The following is a description of a gene set: The presence of any abnormality affecting the abdominal wall. species: Homo sapiens Abnormality of the abdominal wall Human Gene Set: HP_ABNORMALITY_OF_THE_ABDOMINAL_WALL, and this is the list of marker genes: SKIC3, CHD3, CTNNB1, SKIC2, MED13L, ZFP57, TRIM8, IDUA, SET, RIN2, RPL10, SMARCC2, TGFB3, FOXE3, DNAJC30, PIK3CD, SKI, SEC31A, NOTCH2, GLRB, EHMT1, SEMA3E, RNF13, TBXT, ZIC3 (Zic family member 3), GRM7, AP1S2, GNE, CDH11, SETBP1, POU1F1, ATP6V1A, CHD7, LMOD1, MID1, ACTA2, RAC1, FLNB, LRP2, FANCM (FA complementation group M), TGFBR2, CDKN1C, VPS37D, PPP1R12A, ERCC2, AUTS2, DIS3L2 (DIS3 like 3'-5' exoribonuclease 2), CBL, BUD23, SLC5A5, DYNC2I1, GPC3 (glypican 3), SCN2A, FANCF, DUOX2, SNIP1 (NCBI Gene Id 79753), RIPPLY2, PACS1, RRAS, CRKL, ACTG2, MEIS2, MTOR, RFWD3, IKBKG, TMEM67, CDCA7, FOXE1, NFIA, TASP1, FANCI, GTF2I, NOTCH3, SLC2A10, PIGY, PRKG1, SRCAP, KNSTRN, IRX5, PLD1, PIGW, HIRA, MEG3, KMT2D, MBTPS2, MRAS, SMARCA2, AGA, PTCH1, MLXIPL, PIGQ, CAPRIN1, SMAD4, DNMT3B, CTCF, POLR2A, IFT80, ZBTB24, WNT3, AARS1, BCL11B, PNKP, DYRK1A (NCBI Gene Id 1859), LMNA, ABCD4, CHRM3, GTF2H5, CARS1, SALL1, FOCAD, ZEB1, NFIX, UBA1, FLNA, IRF6, B3GAT3, BAZ1B (bromodomain adjacent to zinc finger domain 1B), HES7, RFX7, WDR35, GDF11, CDKL5, KDM3B, CCDC22, GNS, PRKG2, GLB1, RREB1 (NCBI Gene Id 6239), CHAMP1, CLDN19, ATP6V1E1, GPHN, UFD1, APC2, PROP1, DNMT3A, EFNB1, BGN, TSHB, CC2D2A (coiled-coil and C2 domain containing 2A), ZMPSTE24, MYH3, TBX1, MBTPS1, ZBTB7A, DUOXA2, MEGF8, NOTCH1, PIGS, TBCK, DYNC2H1, PRDM5, GJA1 (NCBI Gene Id 7953), EOGT, FRAS1, SLC10A7, FANCA, COX11, TRPV6, ARVCF, NKX2-1, PLAGL1, ABCC8, IGF2, FANCB, PRR12, PIGN, MTFMT, GMNN, PAX8, DLL3, GLIS3, PPIB, ELOVL4 (ELOVL fatty acid elongase 4), TXNL4A, CHUK, DHCR7, ELMO2 (NCBI Gene Id 63916), XRCC4 (X-ray repair cross complementing 4), WDR19, SIK1, SLX4, ATRX, SGSH, RRAS2 (NCBI Gene Id 22800), FGFR1 (fibroblast growth factor receptor 1), MYLK, SMAD2, COLEC10 (collectin subfamily member 10), IFT140, BCOR, FANCC, PLOD2, NEUROD2, FARSB, RPS6KA3, FTO, MMP2 (matrix metallopeptidase 2), SLC35D1, EIF4H, RAB3GAP2, GRIN1, MCOLN1, CSGALNACT1, C1R, MASP1, ERI1, KCNQ1, VPS35L, DGCR6, ODC1 (ornithine decarboxylase 1), ALDH18A1, LFNG, TUBB, RASA2, UBE2T, CWC27, DVL3, USP9X, ARID1A, BRF1, PIEZO2, AMHR2, COL11A2, LRPPRC, KRT1, COL1A1 (collagen type I alpha 1 chain), TGFBR1, UHRF1, RIC1, RIPK4, HSPG2, NAT8L, ATP6V0A2 (NCBI Gene Id 7854), XYLT1, FANCE, FANCD2, FREM2, BRAF (B-Raf proto-oncogene, serine/threonine kinase), FOXF1, DGCR2, LTBP4, STX1A, FZD2, RIT1, LZTR1, ARID1B (AT-rich interaction domain 1B), AMH, CEP120, DACT1, GTF2E2, TGDS (NCBI Gene Id 23483), ATAD1, LHX4, MAT2A, AHDC1, DYNC2I2, OFD1, HEY2, OCLN, CHST14, G6PC3, LIMK1, OCRL, PAH, COL5A1 (collagen type V alpha 1 chain), JMJD1C, CLIP2, IFT81, EED, GRIN2B, HIVEP2, INPP5E (inositol polyphosphate-5-phosphatase E), MYH11, SLC35C1, MAD2L2, KAT6A, ALG9, RAD51, KCNH1, SMARCB1, LONP1, RMRP, BRCA2, SPECC1L, GRIP1, ROR2, RNF2, PLCB4, CCBE1, GTF2IRD2, NDUFA8, SEMA5A, SLC32A1, TENT5A, BCR, TMEM270, GAD1, HIC1, LBR, NSD1, NPHP3, RPGRIP1L, LTBP1, GTF2IRD1, TPO, TMEM94, ERCC3, BSCL2, FAT4, MED12, TARS1, CREBBP, RTL1 (retrotransposon Gag like 1), IFT56, RAF1, THRA (thyroid hormone receptor alpha), MTHFR, YWHAE, DPH1, PI4KA, SLC5A6, SLC26A4, TBX3, LHX3, FKBP6, PYCR1, SLC37A4, HESX1, MAF, KDM6A, TMEM107, HMGA2, FGD1, COL3A1, IPO8, TG, POLR1A, DVL1, MKS1, SH3PXD2B, ZFX, SOS1, PIGL, TAF4, MESP2, SUZ12, COMT, DMXL2, MAN2B1, SEC24C, ERCC4, UPB1, PAFAH1B1, KMT2C, ISL1, TRAF7, TWIST2, HOXC13, BRD4, CTNND2, CHST3, GPC6, ADAMTSL2, COL1A2, EN1, FBXL4, GNB2, NEU1, ALKBH8, C1S, CDC42 (cell division cycle 42), AGPAT2 (NCBI Gene Id 681), SF3B4, CLCN4, KCNQ1OT1, HELLS (helicase, lymphoid specific), PPP2R1A, MPLKIP, TFE3, ELN, EZH2, FBLN5, NEK9, RAB23, SOX6, GATA6, DPP9, SHPK, IFT122, FANCG, KCNA1, MAMLD1, PLAG1 (PLAG1 zinc finger), ADAMTS2, NAA10, GNPAT, DLK1, FKBP14, VANGL2, GNPTAB, CAVIN1, EFEMP1, DICER1 (NCBI Gene Id 4333), KRAS, BRCA1, NUAK2, NKX2-5, FBN1, BRAT1, RFC2, TBL2, GLRA1, PTDSS1, GATA4, SLC6A5, TGFB2, ATP1A2, DDX6, HLA-DQB1, GDF1, NCF1, ACTB, CHRNG, GUSB, IDS, PIGP, COL11A1, FANCL (FA complementation group L), AMER1, TNRC6B, DNAJB4, GALNS, PHGDH (phosphoglycerate dehydrogenase), CRELD1, NECTIN1, RNU4-2, SERPINH1, METTL27, IYD, FIBP, MSX1, HDAC4, LOX, ESS2, DGCR8, AR, PIK3R1, SLC26A2, MFAP5, RAP1B, GLI3, FLI1, TP63, FGFR2, BHLHA9, THSD4, DSE, TRIP11, FBXW11, CASK, NXN, CBS, LDHD, SCN1B, KDM5B, ANTXR1, SPRED2, COL2A1, ARX, COLEC11, HYMAI, SLC25A22, TMCO1, CAMSAP1, TTC7A, ARSB, SLC25A24, TMEM216, FREM1 (NCBI Gene Id 158326), COL5A2 (NCBI Gene Id 1290), CD96, STRA6, ATP7A, GNAO1, MANBA, DLX4, ARPC4, ADAMTS15, GP1BB (NCBI Gene Id 89199), RNF113A, SHOC2, PIEZO1, MAPRE2, CANT1, APC, PPP2CA, PPP2R3C, WNT5A, KCNJ8, STS, TOR1A, NSDHL, NRAS, PORCN, HOXD13, HYLS1, RAD51C, MMP14, PUF60, BMP1, PTPN11, ADNP, BUB1, EFEMP2, KIF7, SOS2, MDFIC, DEPDC5, GPC4, SATB2, DPYSL5, NLRP3, CSNK2A1, SMAD3, WASHC5, TRRAP, TMEM70, KCNJ11, MED25, POGZ, TSHR, PALB2, AEBP1, POLR3GL (RNA polymerase III subunit GL), SMCHD1, MECP2, GZF1, SIN3A (NCBI Gene Id 25942), ABCC9, BRIP1, H19, MAPK1, XRCC2, B3GLCT, NALCN, CUL4B, HLA-DQA1, P3H1, H4C3, BMPER, NIPBL, DPH2, PLOD1, WNK3